Given this list of marker genes RAB7A, BSCL2, ALS2, TBCK, SETX, PMP2, VAMP1, CADM3, DNAJB6, UBA1, SPTAN1, EMILIN1, UQCRC1, SYT2, KARS1, SIGMAR1, here is a description of the gene set: Human Gene Set: HP_DECREASED_COMPOUND_MUSCLE_ACTION_POTENTIAL_AMPLITUDE Decreased compound muscle action potential amplitude Reduced level of the compound muscle action potential (CMAP), which is recorded following electrical stimulation of a nerve from surface electrodes overlying a muscle supplied by that nerve. studied in species Homo sapiens